Given this list of marker genes RAB9A, MAGED4B, GTDC1, CRH, RBPMS, GH2, KLRC2, PTAR1, ZFAND5, ZNF277, EYA4, DCUN1D4, FBXO42, NEB, SH3BP4, INHBB, RPL22L1, ROCK2, C8orf34, KLF7, CBFB, SOCS2, LRRC8C, LARP1, MMP13, KRT14, CERS6, RBM44, SNAP23, RAPGEF2, BFAR, IL1A, PSMA1, FAM110B, DIS3L, TNRC6B, MAGOHB, KLRC1 (NCBI Gene Id 3821), PARP1, OR2H1, EPHA5, RILPL1 (NCBI Gene Id 353116), PSMC2, EMC4, SLC25A37, HFM1, NRXN3, ALDH3A2, ARMC8, MED13, ZNF207, ZNF215, TMEM161B, MYBL1, HIPK3, DKK3, MAGED4, SMIM9, PFN2, SYNJ1, BAG3, BCAP29, PIK3R1, TRAPPC10, LONRF1, ZFAND1, FOXO3, HYAL4, ABHD17B, NMNAT2, MMP8, SPAG1, RLIG1, MIP, PTPN12, SNRPF, ANKRA2, FZD6, CTTNBP2NL, PURB, LYPLAL1, MARCHF2, SLC25A35, EEF1E1, USP10, FMR1, ARID1B, ARHGAP32, TOMM70, HLA-F, KDM6A, RNF141, NCOA2, NEXMIF, HYLS1, FIBP, COL11A1, DCK, FGF13 (fibroblast growth factor 13), INO80D, CCL28 (NCBI Gene Id 56477), CPEB1 (cytoplasmic polyadenylation element binding protein 1), PSMC6, CALM2, GLCCI1, IL9, GH1, ZBTB44, FGA, SLC12A5, LDLRAD4 (low density lipoprotein receptor class A domain containing 4), DAZAP2, ARPC2, ARMCX5, MAFB, DMRT1, TM9SF1, SH2D1A, XPR1, ONECUT2, UBE2D3, NEK7, SZRD1, DNAJB9, SHISA3, DPY19L4, PRR14L, ZNF528, ACADSB (NCBI Gene Id 654185), here is a description of the gene set: from publication Chen Y, Wang X (PMID 31504780) Genes predicted to be targets of miRBase v22 microRNA hsa-miR-891b in miRDB v6.0 with MirTarget v4 prediction scores > 80 (high confidence targets). Human Gene Set: MIR891B species: Homo sapiens